Given this list of marker genes TACR2, CALM1, CFAP52, NHERF1, ODF2, VPS13A, TACR3, HSPD1, TLE6, SPMIP6, SPEF2, AKAP3, ATP1A4, IFT81, TACR1 (tachykinin receptor 1), SLC26A3, SPATA19, CALM3, AKAP4, DEFB1, AK2, CALM2, IFT27, CFAP65, RAP1A, FSIP2, IL4I1, GARIN2, HSP90AA1, RHO, VDAC2, CCDC34, PRKACA, PACRG, NME8, ATG16L1, TBC1D21, SPATA33, LRRC46, TOMM20, GABARAP, CCDC172, GK2, SQSTM1, IFT172, IRGC, PTCHD3, LYZL6, CCR6, CFAP69, CFAP58, SLC26A6, ADGB, CD52, HYAL3, PCDH11Y, TCP11, MROH2B, PPP3R2, here is a description of the gene set: Human Gene Set: GOCC_SPERM_MIDPIECE species: Homo sapiens The highly organized segment of the sperm flagellum which begins at the connecting piece and is characterized by the presence of 9 outer dense fibers (ODFs) that lie outside each of the 9 outer axonemal microtubule doublets and by a sheath of mitochondria that encloses the ODFs and the axoneme; the midpiece terminates about one-fourth of the way down the sperm flagellum at the annulus, which marks the beginning of the principal piece.